The following is a description of a gene set: Genes down-regulated in blood responders vs poor responders in seniors (65-81) (responders (training set)) after exposure to Twinrix, time point 0D. Comment: Network inference based on the 15 markers identified as predictors of the response to the HBV vaccine. species: Homo sapiens Human Gene Set: FOURATI_BLOOD_TWINRIX_AGE_65_81YO_RESPONDERS_VS_POOR_RESPONDERS_TRAINING_SET_0DY_NETWORK_INFERENCE_DN from publication Fourati S, Cristescu R, Loboda A, Talla A, Filali A, Railkar R, Schaeffer AK, Favre D, Gagnon D, Peretz Y, Wang IM, Beals CR, Casimiro DR, Carayannopoulos LN, Sékaly RP (PMID 26742691) Aging is associated with hyporesponse to vaccination, whose mechanisms remain unclear. In this study hepatitis B virus (HBV)-naive older adults received three vaccines, including one against HBV. Here we show, using transcriptional and cytometric profiling of whole blood collected before vaccination, that heightened expression of genes that augment B-cell responses and higher memory B-cell frequencies correlate with stronger responses to HBV vaccine. In contrast, higher levels of inflammatory response transcripts and increased frequencies of pro-inflammatory innate cells correlate with weaker responses to this vaccine. Increased numbers of erythrocytes and the haem-induced response also correlate with poor response to the HBV vaccine. A transcriptomics-based pre-vaccination predictor of response to HBV vaccine is built and validated in distinct sets of older adults. This moderately accurate (area under the curve ~65%) but robust signature is supported by flow cytometry and cytokine profiling. This study is the first that identifies baseline predictors and mechanisms of response to the HBV vaccine., and this is the list of marker genes: HPR, SYDE2 (synapse defective Rho GTPase homolog 2), TOP3A, KIF18B, HP